Given this list of marker genes HLA-DRB1, POT1, PTPN22, P4HA2, SLC34A2, HLA-B, here is a description of the gene set: Nonproductive cough studied in species Homo sapiens A cough that does not produce phlegm or mucus. Human Gene Set: HP_NONPRODUCTIVE_COUGH